The following is a description of a gene set: species: Mus musculus A pentameric complex that includes orthologues of human PIR121, Nap1, Abi, SCAR, and HSPC300 and regulates actin polymerization and/or depolymerization through small GTPase mediated signal transduction. Mouse Gene Set: GOCC_SCAR_COMPLEX, and this is the list of marker genes: Abi3, Wasf2, Cyfip1, Nckap1l, Wasf3, Wasf1, Abi2, Sra1, Abi1 (abl interactor 1), Cyfip2 (NCBI Gene Id 76884), Nckap1, Wmp, Brk1